The following is a description of a gene set: Human Gene Set: HP_COMMON_ATRIUM Common atrium Complete absence of the interatrial septum with common atrioventricular valve and two atrioventricular connections. species: Homo sapiens, and this is the list of marker genes: TBX5, ACVR2B (NCBI Gene Id 93), CLXN, EVC2, MMP21, CIROP, CFAP53, GDF1, ZIC3, IFT56, PRKACB, WT1, EVC